The following is a description of a gene set: species: Mus musculus Mouse Gene Set: WP_SPHINGOLIPID_METABOLISM_OVERVIEW Sphingolipid metabolism overview, and this is the list of marker genes: Kdsr, Cers6, Degs1, Gdf1, Cers3, Plpp1, Degs2, Sptlc1 (serine palmitoyltransferase, long chain base subunit 1), Sgms1, Sgpl1, Cerk, Sgpp2, Ugt8a, Cers2, Sphk1, Sptlc2, Cers4, Smpd1, Sgpp1, Cers1, Ugcg, Sgms2, Plpp3, Sphk2, Asah1